The following is a description of a gene set: species: Mus musculus Mouse Gene Set: GOBP_NUCLEOBASE_CONTAINING_SMALL_MOLECULE_METABOLIC_PROCESS The cellular chemical reactions and pathways involving a nucleobase-containing small molecule: a nucleobase, a nucleoside, or a nucleotide., and this is the list of marker genes: Nme4, Gnpnat1, Parg, Naprt, Elovl5, Uqcc3, Tk1, Slc2a6, Kars1, Slc25a22, Dlat, Cacnb4, Abcc9 (ATP-binding cassette, sub-family C member 9), Cbfa2t3, Pmvk, Ogt, Tdo2, Myh7, Tmsb4x, Dguok, Fam3a, Igf1, Acsm3, Aox1, Ces1d, Mdh2, Nt5c2, Gars1, Ttr, Rpe, Tymp, Entpd4, Haao, Ndufs6, Cox11, Nudt17, Ndufa11, Clpx, Aprt, Acot2, Bcl2l13, Ndufa13, G6pdx, Nudt12, Cad, Pank2, Gapdh, Gamt, Pklr, Dnm1l, Ptgdr, Ldhb, Slc25a12, Tet2, Nupr1, Pde4c, Uchl1, Ak2, Dmac2l, Naxe, Pfkfb3, Nmrk2, Ctps1, Ido2, Fitm2 (NCBI Gene Id 98947), Epha2 (Eph receptor A2), Xdh, Pals1, Pkm (NCBI Gene Id 18746), Vcp, Hmgcl, Il3, Prps2, Mlxipl, Mfn1, Nppc, Ndufb6, Dpagt1, Uox, Eno4, Acsl5, Nudt18, Eno3, Trim63, Gucy2c, Vnn1, Slc25a11, Extl2, Adk, Pnp2, Pde8a, Urad, Map2k1, Dnajc30, Pfkl, Rbks, Acot5, Csgalnact1, Oard1, Nudt1, Htr2a, Rd3, Hspa1b, Tspo, Fcsk (NCBI Gene Id 68821), Uxs1, Esrrb, Naxd (NCBI Gene Id 69225), Crot, Pgk2, Ldha, Ndufs1, Prps1l1, Ndufs5, Got1, Ndufs7 (NCBI Gene Id 75406), Sult2a6, Pmm1, Fis1, Gimap7, Ndufa9 (NADH:ubiquinone oxidoreductase subunit A9), Ampd2, Ndufb11, Pth2, Crmp1, Pudp, Atp5po, Gcdh, Qng1, Ndufb5, Ndufv3, Hnf1a (HNF1 homeobox A), Slc2a1, Pcx, G6pd2, Elovl4, Adpgk, Stoml2, Lipa, Gfus, Ndufb7, Pank1, Shmt2, Dhtkd1, Dut, Adss1, Gnpda2, Enpp3, Tpk1, Mvk, Stat3, Nnmt, Gapdhrt, Hdac4, Ugp2, Nt5c1b, Col6a1, mt-Nd6, Sdhd, Ctps2, Adora2b, Actn3, Sult2a2, Atp5mf, Foxk2, Pdk1, Dpysl2, Cs, Nudt5, Shmt1, Taldo1, Bpgm, Slc1a3, Nadsyn1, Acaca, Ndufb10, Adcy10, Git1, Ndufb3, Dhfr, Ndufs3, Tkt, Adsl, Acot9, Nme6, Acot4, Enpp5, Sirt6, Ldhc, Oxct2a, Mlycd, Guca1b, Slc37a2, Acsl4, Acsl1, Sdhc, Far1, Icmt, Pgm2, Sult2b1, Fuom, Eno1, App, Atp1a2, Sult2a5, Pdhb, Adcy1, Parp14, Prkag3, Acaa2, Pgam2, Glyat, Atp5pf (ATP synthase peripheral stalk subunit F6), Gfpt1, Acot11, Ucp2, Nmnat3, Pank3, Pde5a, Trp53, Ak7, Gnmt, Hif1a, Pde8b, Rfk, Cmpk2, Atp6v1b1, Ndufa2, mt-Nd5, Fpgt, Eif6, Cnp, Dpyd, Rnaseh2b, Dtymk, Tigar, Uckl1, Pdhx, Dlst, Mgat1 (NCBI Gene Id 17308, mannoside acetylglucosaminyltransferase 1), Nadk, Nans, Mpi, Idh2, Dip2a, Kat2b, Uck1, Hmgcs2 (3-hydroxy-3-methylglutaryl-Coenzyme A synthase 2), Gpat4, Acot8, Entpd4b, Uck2, Sult1b1, Them5 (NCBI Gene Id 68547), Sult2a1, Slc35a1, Atp1b1, Rrm2b, Gucy2g, Nme3, Dcxr, Elovl1, mt-Atp6, Ndufa1, Letmd1, Sult1e1, Upb1, Acot1 (NCBI Gene Id 28195), Hprt1, Mtap, Acsm4, Atp5f1c, Zbtb20, Ndufv1, Gnpda1, Atp6v1a, Cant1, Acss2, Enpp1, Oasl2, Alpi, Aass, Acnat1, Pde2a, Foxk1, Trem2, Gnai3, Elovl3, Ncf2, Rhoq, Dld, Idh1, Ogdh, Lacc1, Efl1, Aco1, Cda, Acot7, Sult1c1, Cmpk1, Ncf1, Eno1b, Adss2, Amdhd2, Csl, Gale, Atp5f1d, Nt5m, Cmas, Dera, Paics, Kynu (kynureninase), Ak5, Dctpp1, Ppcs, Pycr3, Adcy6, Mlst8, Nt5e, Rab23, Ampd3, Npr1, Suclg2, Ahcyl, Npr2, Gart, Gapdhs, Prps1l3, Ndufa8, Noct, Nudt4, Got2, Ampd1, Uap1l1, Acp3, Slc4a1, Gucy1a1, Hsd17b4, Dck, Adcy3, Atp5f1b, Smpdl3a, Pid1 (NCBI Gene Id 98496), Papss2, Aldoa, Sult2a8, Myog, Lrrk2, Atp5pd, Acadsb, Aldob, Pfas, Gpi1, Mtor, Me1, Gmds (NCBI Gene Id 97904), Mcee, Ndufb2, Ndufc1, Atp5me, Pdha2, Tbpl1, Gucy2f, Nme1, Pdk3, Ndufa5, Slc52a3, Acot12, Slc25a13, Pemt, Parp1, Sdhb, Sphk2, Pgd, Pipox, Cps1, Kmo, Ppcdc, Entpd8, Ndufa10 (NADH:ubiquinone oxidoreductase subunit A10), Ndufs2, Gfpt2, Macrod1, Myh6, Mtch2, Ifng, Sucla2, Acot3, Gpd1l, Gpam, Suclg1, Abcc6, Prpsap1, Ins1, Dpys, Gpd2, Gck, Atp5mc2, Guca1a, Hnf4a, Entpd5, Slc4a7, Ndufs4, Dgat2, Dpysl5, Fignl1, Bend3, Atp6-ps, Urah, Insr, Macrod2, Ak1, Pde10a, Tpi1, Prpsap2, Mpc1, Pgk1, Prkn, Bcl2l1, Slc52a2, Fhit, Afmid, Ak6, Hmgcr, Oga, Dcakd, Acsm1, Nmrk1, Sult2a4, Pcmt1, Prkaca, Elovl6, Gucy2d, Rrm1, Nme7, Fbp1, Atp6v1b2, Atp5mg, Entpd3, Slc25a18, Samhd1, Dgat1, Nme5, Atp5mc1, Umps, Flad1, Nme2, Impdh2 (inosine monophosphate dehydrogenase 2), Mccc2, Nudt14, Vdac1, Impdh2-ps, mt-Nd4, Pgm3, Aspdh, Atp5f1e, mt-Nd4l, Ada, Acacb, Hmgcs1, Ak4, Atp5if1, Uggt1, Hk1, Ndufb4, Nudt7, Arl2, Cfh, Acot6, Dctd, Fmo2 (flavin containing monooxygenase 2), Zbtb7a (NCBI Gene Id 71606), Prkag1, Bad, Gtpbp1, Hk3, Ak8, Adcy2, Upp1, Acsm5, Tkfc, Gmppb, Nudt9, Uprt, Nadk2, Atp5f1a, Nt5c, mt-Nd2, Mpc2, Aldoart2, Ehhadh, Rora, Acnat2, Ppargc1a, Adcy5, Ldhd, Prkag2, Khk, Nudt16, Gucy1b1, Pde9a, Cyb5r4, Sult2a3, Ran, Nudt19, Ndufab1, Ugdh, Atic, Pde7b, Atp2b2, Prps1, Snca, Ndufa3, Nudt15, B3galnt2, Ndufb8, Atg5lrt, Slc35c1, Galk1, Nos3, Nnt, Galt, Coasy, Impdh1, mt-Nd3, Pank4, Antkmt, Trex1, Opa1, Nanp, Art2b, Ndufa6, Ndufs8, Gmpr2, Slc25a42, Tk2, Pfkm, Nmnat2, Rpia (NCBI Gene Id 19895), Baat, Adcy8, Il4, Gapdhrt2, Ndufa12, Pgls, Mlx, Pde4a, Selenon, Mmaa, Mdh1, Tgfb1, Aldoc, Ndufv2, Nppa, Myh8, Dpm1, Ins2, Entpd2, Pfkfb1, Fkrp, Ep300, Ctns, Pals2, Aldh1l1, Dhodh, Pdha1, Gucy2e, Ncor1, Sik2, Jmjd8, Ppp2ca, Flcn, Hk2, Sdha, Aldh1l2, Park7, Prkaa2, Nudt10, Nudt13, Atp5pb, Enpp4, Hint1, Ido1, Atp5mc3, Itpa, Rptor, Nudt3, Cdadc1, Ddit4, Qprt, Hspa8, Hkdc1, Entpd1, Nppb, Pdk2, Myh3, Guk1, Mvd, Aadat, Slc29a1, Ola1, Nudt8, Papss1 (3'-phosphoadenosine 5'-phosphosulfate synthase 1), Entpd7, Kdm1a, Eno2, Fut8, Far2, Pfkp, Acly, Adcy4, Slc25a51, Hsd11b1, Pde7a, Gda, Ak9, Sult2a7, Aldh6a1, Dpysl3, Slc27a3, Prkaa1, Pgam1 (NCBI Gene Id 68006), Pnp, Me2, Gmps, Acsl6, Ak3, Pde4d, Pmm2, Acat1, Sarm1, Fasn, Dpysl4, Gpd1, Hrh3, Tyms (thymidylate synthase), Shpk, Slc25a16, Nt5c3, Acss1, Nudt11, Tgds, Nt5c1a, Atp7a, mt-Atp8, Pdk4, Src, Cmah, Adcy7, Nt5c3b, Mthfd1, Nampt, Acsl3, Oas1a, B4galnt2, Atpsckmt, Ier3, P2rx7, Dnph1, Psen1, Myc, Mthfd2l (NCBI Gene Id 68621), Ahcy, Acsm2, Slc4a4, Mmut (methylmalonyl-Coenzyme A mutase), Macroh2a1, Ppat, Oxsm (3-oxoacyl-ACP synthase, mitochondrial), Pfkfb2, Gne, Nudt2, Art2a, Arnt, Upp2, Ndufc2, Ppara, Ndufb1, Mdh1b, Elovl7, Bckdk, Gmppa, Rhoa, Rrm2, Gmpr (NCBI Gene Id 66355), Adal, mt-Nd1, Aldoart1, Ndufb9, Nmnat1, Mfsd8, Ndufa7, Bloc1s6, Uap1, Adcy9, Mapk1, Prxl2c, Aicda, H6pd, Pde1a, Slc25a25, Abcd1, Acot10